Given this list of marker genes THAP12P5, NDEL1, SPANXB1, PCM1, RNU4-71P, ARPP21, CELF2, SLC35A5, RPL5, H3C7, SLC25A21-AS1, ZBTB46-AS1, CFL1P7, NDUFS2 (NADH:ubiquinone oxidoreductase core subunit S2), PLAUR, PKIB, ENSG00000202537, GPR160P1, RFX2, RIMBP2, SELENOWP1, DGKA, NFKB2, ENSG00000252904, PYM1, SETP11, TTN-AS1, ADAT1, RPL34P11, SLC1A4, LINC01620, ZNF624, LINC00339, BZW2, RN7SL404P, YWHAEP1, PRKCH, GAPDHP55, IL17RD, LYRM4, ENTPD5, MIR4422HG (MIR4422 host gene), C12orf75, ENSG00000260005, UBE2Q2, MAP2K6, RNU6-226P, NEMF, RAB3IP, BTK, SNRPGP1, B3GNTL1P2, IFNGR1, YWHAEP5, SPTBN2, FNBP1L, HYDIN, ATXN2, USP6NL, BANP, RPS23P9, AGK, ZMYM4, LINC02013 (NCBI Gene Id 105374272), MIR3910-1, ENC1, MIOS-DT, VPS51, CHN1, THRB-AS1, MTCO3P12, SAMD14, BLM, ANKMY2, MGP, ENSG00000247131, TK2, RNU6-1078P, MIR204 (microRNA 204), FBXO38, RASA2, MIR548E, MIR4711 (microRNA 4711), YWHAE, FAM230G, PDZRN3, DCLRE1C, TMEM30B, DDX39A, LINC01585, PHLPP1, IL6ST, ARHGAP27, SETP16 (SET pseudogene 16), MTIF2, H3P3, MITF, GPR85, RDH12, SLC6A15, TMEM116, P4HA2, SLC26A10P, DISC1, PIGFP2, ZNF790, MIR3910-2, RPS15AP16, CTBP2 (C-terminal binding protein 2), MTND5P11, C18orf21P1, RNU6-1128P, MARK4, ZNF345, ZFPM2, ANKS1B, LINC02940, KRBOX5, FSIP2LP, MMS22L, RN7SKP153, RNU6-409P, LINC00343, MMP24OS, RNY3P4, RPS13P3, MARCHF6, ENSG00000271860, H2BC9, RAPGEF2, PDCL3P6, here is a description of the gene set: from publication Yevshin I, Sharipov R, Kolmykov S, Kondrakhin Y, Kolpakov F (PMID 30445619) Genes containing one or more binding sites for (ZFP28) in their promoter regions (TSS -1000,+100 bp) as identified by GTRD version 20.06 ChIP-seq harmonization. Human Gene Set: ZFP28_TARGET_GENES species: Homo sapiens